Given this list of marker genes HID1, CHMP7, CHMP4B, CHMP6, CHMP5, CHMP3, CHMP2A, VPS16, CHMP1A, CHMP2B (charged multivesicular body protein 2B), CHMP4C, CHMP4A, CHMP1B, here is a description of the gene set: species: Homo sapiens Merging of two or more vacuoles, or of vacuoles and vesicles within a cell to form a single larger vacuole. Human Gene Set: GOBP_VACUOLE_FUSION